The following is a description of a gene set: Reactome Pathway: Polo-like kinase mediated events electronically inferred by orthology from the curated human pathway This event has been computationally inferred from an event that has been demonstrated in another species.<p>The inference is based on the homology mapping from PANTHER. Briefly, reactions for which all involved PhysicalEntities (in input, output and catalyst) have a mapped orthologue/paralogue (for complexes at least 75% of components must have a mapping) are inferred to the other species. part of: G2/M Transition species: Mus musculus, and this is the list of marker genes: Plk1, Cdc25c, Wee1